Given this list of marker genes Selenos, Edem2, Aup1, Svip, Faf2, Os9, Sel1l, Nploc4, Derl3, Derl1, Edem1, Tmem129, Bcap31, Vcp, Ubac2, Derl2, Sec61b, Ufd1, Yod1, H13, Rhbdd1, Erlec1, Ube2j1, Afg2b, Hsp90b1, Syvn1, Sec61bl, Herpud1, Ube2g2, here is a description of the gene set: Mouse Gene Set: GOBP_ENDOPLASMIC_RETICULUM_TO_CYTOSOL_TRANSPORT The directed movement of substances from endoplasmic reticulum to cytosol. studied in species Mus musculus